The following is a description of a gene set: Mouse Gene Set: GOMF_CYTOSKELETAL_MOTOR_ACTIVITY Generation of force resulting in movement, for example along a microfilament or microtubule, or in torque resulting in membrane scission or rotation of a flagellum. The energy required is obtained either from the hydrolysis of a nucleoside triphosphate or by an electrochemical proton gradient (proton-motive force). studied in species Mus musculus, and this is the list of marker genes: Kif19b, Dnah7a, Myh14, Myh15 (myosin, heavy chain 15), Kif1c, Myo1g, Myo1d, Kif19a, Myl6, Dnah2, Kif3a, Kif13a, Myo1b, Myh13, Cenpe, Dync1i1, Myo3b, Kif13b, Kif26a, Myo6, Myo1h, Kifc2, Kif18a, Kif17, Tnnt2, Dnai2, Myh7, Kif4, Kif22, Dnah1, Myo1e, Dnah10, Kif18b (NCBI Gene Id 70218), Myo3a, Myh3, Dnah6, Myo19 (myosin XIX), Myo1f, Dnah17, Myh9, Myo1c, Dnah11, Kifc1, Dnah8, Dnah9, Kifc5b (NCBI Gene Id 94117), Dnah14, Actc1, Kif1b, Kif14, Kifc3, Kif23, Kif9, Myo5c, Kif16b, Myh7b, Kif12, Kif11, Kif5a, Stard9, Myo1a, Myo16, Kif1a, Kif26b, Myh2, Kif21a, Kif20a, Kif7, Myh11, Myh8, Kif3c, Kif28, Myh6, Clxn, Dnah7c, Kif2b, Myo15a, Pmp22, Myo5a (myosin VA), Dync1li1, Dnhd1 (dynein heavy chain domain 1), Myh4, Myl6b, Dync2h1, Myh10, Pin1, Dnah7b, Dync1h1, Myo9b, Myo5b, Kif2c, Gpr88, Kif21b, Kif3b, Kif24, Kif15, Kif27, Myh1, Dnah12, Kif6 (NCBI Gene Id 328835), Dbn1, Myl3, Dnah5, Myo10, Kif2a, Kif20b, Dnah3, Kif5b, Kif5c, Myo7a, Myo7b, Myo9a (NCBI Gene Id 319681)